Given this list of marker genes Gemin5, Snrpa, Snrnp70, Prpf8, Snrpb2, Snrpc, Coil, Isg20, here is a description of the gene set: species: Mus musculus Binding to a U1 small nuclear RNA (U1 snRNA). Mouse Gene Set: GOMF_U1_SNRNA_BINDING